The following is a description of a gene set: Genes predicted to be targets of miRBase v22 microRNA hsa-miR-938 in miRDB v6.0 with MirTarget v4 prediction scores > 80 (high confidence targets). from publication Chen Y, Wang X (PMID 31504780) Human Gene Set: MIR938 studied in species Homo sapiens, and this is the list of marker genes: SACS (NCBI Gene Id 26278), ZNRF1, PNKD, PRDM8, ZBTB34, CLCN4, SLC11A1, IRF8, NCS1, GPC6, IL17A, HOMER2, PREP, DGKI, APAF1, UBE2W, PDP1, EFNA1, ZNF827, WWC1, YES1, USP25, DGKH, FNDC5, ADM, SHISA6, MAP2K4, RBM33, BZW1, MSRB3, CREB5, GNB1, FAM210B, TTC17, SFR1, ERVMER34-1, NTNG1, CREBRF, TMEM97, SPRED2, FAM219B, CPT2, AFF4, RICTOR, RBM5, TOMM20, WDFY4, RCHY1, TRIB1, SLC8A3, SSH2, HERPUD2 (NCBI Gene Id 64224), ATP2C1, ACAT2, SFXN1, HNRNPA3, EPAS1, KCNK10, TNRC6C, SDHD, STIM2, H2AX, TIAM1, H3-3B, PRCP, GPRIN2, FHL1, NTN4, NPTN, SESTD1, DENND6A, MOB1B, EED, LIMA1, SMAP1